The following is a description of a gene set: species: Homo sapiens Human Gene Set: MISIAK_ANAPLASTIC_THYROID_CARCINOMA_UP from publication Misiak D, Bauer M, Lange J, Haase J, Braun J, Lorenz K, Wickenhauser C, Hüttelmaier S (PMID 34885022) Genes up-regulated in anaplastic thyroid carcinoma and sharply distinguishing ATC from other thyroid carcinomas. Anaplastic thyroid carcinoma (ATC) is the most fatal and rapidly evolving endocrine malignancy invading the head and neck region and accounts for up to 50% of thyroid cancer-associated deaths. Deregulation of the microRNA (miRNA) expression promotes thyroid carcinoma progression by modulating the reorganization of the ATC transcriptome. Here, we applied comparative miRNA-mRNA sequencing on a cohort of 28 thyroid carcinomas to unravel the association of deregulated miRNA and mRNA expression. This identified 85 miRNAs significantly deregulated in ATC. By establishing a new analysis pipeline, we unraveled 85 prime miRNA-mRNA interactions supporting the downregulation of candidate tumor suppressors and the upregulation of bona fide oncogenes such as survivin (BIRC5) in ATC. This miRNA-dependent reprogramming of the ATC transcriptome provided an mRNA signature comprising genes sharply distinguishing ATC from other thyroid carcinomas. The validation of the deregulated protein expression in an independent thyroid carcinoma cohort demonstrates that miRNA-dependent oncogenes comprised in this signature, the transferrin receptor TFRC (CD71) and the E3-ubiquitin ligase DTL, are sharply upregulated in ATC. This upregulation is sufficient to distinguish ATC even from poorly differentiated thyroid carcinomas (PDTC). In sum, these findings provide new diagnostic tools and a robust resource to explore the key miRNA-mRNA regulation underlying the progression of thyroid carcinoma., and this is the list of marker genes: RRM2, SMTNL2, HIF3A, B4GALNT4, OTX1, HCN1 (NCBI Gene Id 609), PTH1R, NDNF, TFRC, GPC1, PCDH19, COL20A1, MME, IGF2BP1, SLC22A7, FZD10, SERPINE1, TBL3, SLC7A5, LMNB1, GREM1, PRLR, ARID3A, GINS1, PAX3, SH2D4B, CHEK1, MYO18B, SIX4, MAD2L1, ARL2, POU3F2, NRXN2, HMGA1, HES7, KLHL33, TRIM9, BIRC5 (baculoviral IAP repeat containing 5), ACTC1, SPC24 (SPC24 component of NDC80 kinetochore complex), KAZALD1, SCD, SP6, DTL, MYLK